Given this list of marker genes BUB1, SIX4, TJP3, OLFM4, VCAN, NOXO1, ITGA2, VSTM2L, SLC4A11, GPRC5A, C19orf33, CYP2S1, CTSE, EPS8L1, LAMB3, TOP2A, RHBDL2, AUNIP, MSLN, TFCP2L1, NFE2L3, CLIC3, ST6GALNAC1, LIPH, BORA, AURKA, KLK6, SLC16A3, ZBED2, VILL, KRT17 (keratin 17), VDR, CDCA3, SERPINB2, MYO1A, BCO1, LGALS3, PLEK2, SERPINB5, CEACAM6, MYOM3, TSPAN1, KIF11, CTSV (NCBI Gene Id 1515), CAPG, SLC39A4, CST6, NRP2, CDH17, CEACAM5, PMAIP1, SMPDL3B, SPIRE2, SPOCD1, REG4, HOXB7, FGFBP1, SCIN, PSCA, HSPA1B, PLBD1, NMU, HK2, PKP3, LEMD1 (LEM domain containing 1), KLK7, BIK, FA2H, HSH2D, S100P, STYK1, MMP12, DHDH, PPP1R14D, CCNB2, NOX4, USP54, ALDH3B1, MXRA5, QPCT, GCNT3, FAM83D, ADGRF1, CDX2, C1GALT1, DTX2, GJB4 (NCBI Gene Id 2708), EPHX3, ANLN, AP1S3, CLDN4, SCEL, UNC93B1, SAPCD2, GJB5, TMC7, LAMC2, GPR160, ELL3, CENPE, GJB3, KRT19, KCNK1, GPA33, FXYD3, SOX21, COL12A1, PTK6, KLF5, CDC20, KCNN4 (NCBI Gene Id 3783), UBE2C, CDCP1, MYH14, BCL11B, PLAC8, MECOM, LGALS4, CTHRC1, GPR87, APOBEC1, ADAM8, OLR1, TTK, GALNT6, COL11A1 (NCBI Gene Id 317718), COL1A2, GALNT12, CDH3, IGFL2, SLC6A14, BCL2L15, KLK10, ITGB6, ASPHD2, C15orf48, CKMT1B, BHLHE41, MUC17, COL6A3, KRT6B, ANKRD22, MYB, ANXA3, MYEOV, DLGAP5, LPAR5, CORO2A, FERMT1, ST14, CEMIP, GPR35, C1orf116, DKK1, TUFT1, KRT20, ARHGAP27, TRIM31, CD55, TPX2, PPP1R1B, PLAUR (plasminogen activator, urokinase receptor), MISP, WNK4, SFN, PTPRR, MTMR11, KRT15, CEP55, DAPP1, SLC6A20, KIF15, TMPRSS4, CBLC, PLA2G10, here is a description of the gene set: species: Homo sapiens Human Gene Set: ANDERSEN_CHOLANGIOCARCINOMA_CLASS2 Genes overexpressed in cholangiocarcinoma class 2 associated with poor prognosis. from publication Villanueva A, Hoshida Y, Battiston C, Tovar V, Sia D, Alsinet C, Cornella H, Liberzon A, Kobayashi M, Kumada H, Thung SN, Bruix J, Newell P, April C, Fan JB, Roayaie S, Mazzaferro V, Schwartz ME, Llovet JM (PMID 21320499) In approximately 70% of patients with hepatocellular carcinoma (HCC) treated by resection or ablation, disease recurs within 5 years. Although gene expression signatures have been associated with outcome, there is no method to predict recurrence based on combined clinical, pathology, and genomic data (from tumor and cirrhotic tissue). We evaluated gene expression signatures associated with outcome in a large cohort of patients with early stage (Barcelona-Clinic Liver Cancer 0/A), single-nodule HCC and heterogeneity of signatures within tumor tissues.